The following is a description of a gene set: Human Gene Set: GSE11961_MARGINAL_ZONE_BCELL_VS_PLASMA_CELL_DAY7_DN To obtain insight into the genetic basis of the increase of functional activity of memory B cells over time, we compared the gene expression profiles of day 7 and day 40 NP-specific/IgG1 memory B cells, GC B cells and plasma cells in immunized WT mice and naïve B cells, before and after activation in vitro. Genes down-regulated in marginal zone B cells versus day 7 plasma cells. species: Homo sapiens from publication Kaji T, Ishige A, Hikida M, Taka J, Hijikata A, Kubo M, Nagashima T, Takahashi Y, Kurosaki T, Okada M, Ohara O, Rajewsky K, Takemori T (PMID 23027924), and this is the list of marker genes: SERPINI2, INTS11, DYRK2, NSUN5, SHMT1, SYCE3, KLRG1, UBXN11, RAPH1, DLGAP1-AS1, ITK, GPR171, WNT3, SPN, PECAM1, AKAP8, CNOT6L, MOXD1, QPRT, THOC7, NCDN, TSPAN5, SPATA13, UBAC2, INTS12, GALK1, DNAI4, CIPC, ILF2, ESPL1, DEF6, SLC7A9, XRCC5, PDE3B, RSAD1, PRIM1, TUT4, ANKRD24, ZNRF3, RHOQ, ZNF598, LRP12, ABLIM1, C15orf61, ZNF7 (NCBI Gene Id 7553), ST3GAL4, CFAP298, TTPAL, PSME3, PDCD6, TSEN15, SH2D1B, LGALS4, NUCB1, KCNU1, REC114, ITGAL, RBM28, NFATC3, IL18R1, SNRPC, FHL2, USP43, PASK (NCBI Gene Id 26144), GNPTG, CARNMT1, GNGT1, METRN, G2E3, CACNG5 (calcium voltage-gated channel auxiliary subunit gamma 5), SNRNP48, C6orf118, HPRT1, RBM10, EMILIN2, KCNK7, IL2RB, PSMD1, VMP1, PLEC, C19orf48P, SKIC8, SKAP1, RBL2, MR1 (NCBI Gene Id 3140), TXNL1, ERCC4, SIMC1, ABCB6, UNC79, ERI2, DUT, FAAP24, LTV1, SSBP2, NIBAN2, CENPW, MIGA2, NDUFAF4, PRIM2, FURIN, ZDHHC22, NCALD, SLC35D1, VWA8, LY6G6D, VIP (NCBI Gene Id 7432), B3GNT7, EED, UTP4, HACD3, RCN1, WDR75, FIRRM, CBX7, ERI1, CD244 (NCBI Gene Id 51744), MLANA, NCMAP, FBP1, ADAM7, ERRFI1 (ERBB receptor feedback inhibitor 1), GTSE1, CDCA3, LGALS1 (galectin 1), SPTBN1, ATP1B1, RAD54B, NAA16, GRAMD4, MEMO1, CA14, SPRY2, RAI2, C1orf174, FOXO1, ABCG2, ANP32A, RNF43, PLEKHF1, PADI1, SARS1, UNC5A, PTGR1, CD72, PANX1, GNB1L, SEC16B (NCBI Gene Id 89866), GMFG, TSC22D4, EGLN3, TTI2, KDM4D (NCBI Gene Id 55693), KLRC3, CCNH, RRP1B, BAIAP3, HASPIN, ULK2, GAB3, ACD, TPST2, WDR3, CYP39A1, PARP2, FYB1, CTPS1, RIOK1, SLC30A6, NTPCR, BRINP2, PSMG2, ABRACL, COBLL1 (cordon-bleu WH2 repeat protein like 1), DIMT1, ZNF711, DDX24, VOPP1, HACD1, CDC7, SELENOP, TIMM50, ATP2B1, CD2, DNAAF2, NME7, FAM78A, MLLT6, EMP1, CTU1, COX11, FANCD2, FAM110B, ZNF560, CD247, ORC1, PAFAH1B2, TULP4, TXNL4B